The following is a description of a gene set: Mouse Gene Set: GOBP_MUSCLE_CONTRACTION studied in species Mus musculus A process in which force is generated within muscle tissue, resulting in a change in muscle geometry. Force generation involves a chemo-mechanical energy conversion step that is carried out by the actin/myosin complex activity, which generates force through ATP hydrolysis., and this is the list of marker genes: Adora2b, Gdnf, Stac3, Atp2b4, P2rx3, Dlg1, Ctnna3, Akap6, Smpd3, Dock5, Neurog1, Adrb1 (adrenergic receptor, beta 1), Grcc10, Myom2, Scn1a, Adra2a, Ptger4, Mylk2, Ank2, Chrnb4, Map2k3, Rps6kb1, Sumo1, Tpcn2, Adra2b, Kcnn2 (potassium intermediate/small conductance calcium-activated channel, subfamily N, member 2), Pgam2, Kcnd3, Cert1, Smad5, Sgcd, Prkca, Tmod1, Hdac4, Scn1b, Myl3, Zfas1, Stc1, Adora1, Chrm3, Trpm4, Selenon, Calm1, Tbx2, Actn3, Kcne3, Calm3, Htr7, Dock4, Mybpc1, Chrna3, Cd38, Edn2, Zdhhc21, P2rx1, Lmod3, Tnni2, Cacna1d, Atp1a1, Sstr2, Smtn, Slc8a1, Tafazzin, Tnnc1, Myh4, Cald1, Ace2, Adcy10, Myh6, Mylpf, Pla2g6, Kcnd2, Dsg2, Slc8a3, Tpm1, Gucy1a1, Ttn, Nmur1, Bin1, Myh2, Myl1, Kcnj8, Actn2, Scnn1b, Sulf1, Cttn, Dbn1, Rap1gds1, Uty, P2rx4, Tbx3, Pde4b, Rangrf, Kcnj5, Ryr2, Gata4, Ada (adenosine deaminase), Flt1, Myl2, Atp1a2, Tnnc2, Itga2, Sri, Kcnma1, Tnnt3, Ptger3, Anxa6, Cacna1h, Kbtbd13, Dsc2, Irag1, Ormdl3, Casq1, Tmod2, Klk1b1, Nos1, Chrng, Gpd1l, Tacr3, Tacr1, Rcsd1, Clcn1, Kcnip1, Kcnq1, Tnnt1, Adra1b, Hcn4, Psen2, Chrnd, Prkg1, F2r, Aldoa, Adra2c, Drd1, Chga (chromogranin A), Cacna2d1, Kcne1, Nmu, Nr4a1, Kcnh2, Fkbp1a (FK506 binding protein 1a), Ndufs6, Ptafr, Apbb1, Myocd, Rhoa, Eno1b, Met, Myl6b, Tpm4, Tmem38b (NCBI Gene Id 72005), Apbb2, Pde4d, Ccdc78, Trpv4, Jsrp1, Tnni3k, Myh3, Bmp10, Agrn, Snta1, Vegfb, Adrb2, Bbs2, 3425401B19Rik, Trpv1 (transient receptor potential cation channel, subfamily V, member 1), Lmod2, Mybpc2, Mylk, Npy2r, Pln, Pde5a, Tnnt2, Strit1, Dsp, Myh8, Csrp3, Adra1a, Fxyd1, Mybpc3, Calcrl, Spx, Atp2b1, Agt (angiotensinogen), Trpa1, Jup, Nup155, Cacnb2, Dmd, Kcnip2, Chrnb1, Ryr3, Chrnb2, Tbx20, Map2k6, Npnt, Cacna1s, Stub1, Mtor, Edn1, Gper1, Myl6, Hsbp1, Tnni1, Prok2, Scn4b, Kit, Scn3b, Ppp1r13l, Oxtr, Cacna1g, Fgf13, Cav1, Myh13, Scn11a, Glra1, Ryr1, Grk2, Tpm3, Slc9a1, Npy1r, Srf, Ccn2, Kcne4, Myl4, Fkbp1b, Stac2, Scn2b, Smad7, Ehd3 (EH-domain containing 3), Atp8a2, Tpm2, Gja5, Homer1, Rnf207, Pawr, Comp, Scn4a, Vps54, Nedd4l, Chrna1, Casq2, Ptgs2, Lmod1, Scn10a, Ghrl, Gsn, Ednra, Calm2, Nkx2-5, Tmod3, Srsf1, Myh7b, Tifab, Map2k1, Sphk1, Large1, Chrm2, Ddit3, Lck, Hsp90aa1, Myh7, Grip2, Chrne, Gaa, Shc1, Prkd1, P2rx2, Tpm3-rs7, Tcap, Nppa, Tacr2, Trim63, Myom1, Scn5a (NCBI Gene Id 20271), Atp2a1, Arg2, Flna, Ghsr, Bdkrb2, Htr2b, Actc1, Cxcr4, Rock2, Setd3, Ucn, Myh14, Tnni3, Sod1, Ednrb, Mkks, Pkp2, Atp1b1, Synm, Eno1, Cav3 (NCBI Gene Id 12391), Edn3, Rgs2, Calca, Abat, Fkrp, Arhgap42 (NCBI Gene Id 71544), Zc3h12a, Cacnb1 (calcium channel, voltage-dependent, beta 1 subunit), Kcne5, Cacng1, Ptgs1, Kcne2, Atp2a2, Abcc9, Tmem38a, Tnf, Tbxa2r, Htr2a, Kcna1, Rem1, Cacna1c, Oxt, Htr1d, Kcna5, Myh1, Camk2d, Tshz3, Drd2, Tmod4, Sulf2, Acta2, Dmpk, Akap9, Myh11, Kcnj2, Stac, Pik3ca, Atp1a3